The following is a description of a gene set: The process in which an antigen-presenting cell expresses antigen (peptide or lipid) on its cell surface in association with an MHC class Ib protein complex. Class Ib here refers to non-classical class I molecules, such as those of the CD1 or HLA-E gene families. Human Gene Set: GOBP_ANTIGEN_PROCESSING_AND_PRESENTATION_VIA_MHC_CLASS_IB species: Homo sapiens, and this is the list of marker genes: HLA-E, RAET1E, HLA-G, TAP2, CD1A (NCBI Gene Id 909), HLA-F, ULBP3, HLA-B, AP3D1, HLA-H, HLA-C, ULBP2, CD1C, HLA-A, RAET1L, AZGP1, ULBP1, CD1D, RAET1G, B2M, CD1B, CD1E, AP3B1